Given this list of marker genes Ahr, Slc46a3, Cyp1a1, Pde2a, Tiparp, F7, here is a description of the gene set: Any process that results in a change in state or activity of a cell or an organism (in terms of movement, secretion, enzyme production, gene expression, etc.) as a result of a 2,3,7,8-tetrachlorodibenzodioxine stimulus. studied in species Mus musculus Mouse Gene Set: GOBP_RESPONSE_TO_2_3_7_8_TETRACHLORODIBENZODIOXINE